Given this list of marker genes KCNA5, C1QC, TRDMT1, ST8SIA1, RASL11A, IGF1R, OR1E3, FOXD1, PSMB2, KCNJ11 (potassium inwardly rectifying channel subfamily J member 11), HTR1A, GSTM1, CEBPE, GLI4, CHORDC1, GRID1, KLF10, SMYD5, SCN7A, PNLIPRP1, EFEMP1, ST6GALNAC3, SPAM1, TRBV15, CA2, ATP9A, RHD (Rh blood group D antigen), ADAP1, PCK1 (NCBI Gene Id 5105), TMT1B, CYP11B2, ABCC9, GIP, CEACAM3, PRR4, PZP, INPP5D, NF2, KCNJ2, GMPR, CDC37, DNAH2, GCM1, NEURL3, DIO2, PLG, COMP (cartilage oligomeric matrix protein), CHIC1, GNG7, GPR19, NPPC, TRH, CHCHD6, AVPR1B, DRD3, LCN2, MARK2, TACR1, HAL, MAP2K2, PTH, CLEC11A, PROC, SV2B, KLF6, IRS2, CYP2D6, ZSWIM7, GRHPR, ERGIC1, CBX5, F2RL1, CAMK2N2, GRM5, KCNJ4, CHN1, CD3D, GHSR, CDS1, PFKM, AZGP1, KCNA6, MYH3, RALBP1, ATP4B, CYP2E1, SCNN1B, GRM8, SSTR1, CAMK1D, MC3R, ITGAE, CD52, CUZD1, CYP27B1, UCHL1, CBS, PCCB, INF2, IGF2R, ARRB2, ZNF45, PNOC, SERPINA1, PLAAT5, SULT1C2, TAP1, ACP3 (acid phosphatase 3), MEF2D, PLA2G2A, VIM, CHRNA4, SLC10A1, CRYBB3, PAQR7, SLC13A2, PDE4C, ACCSL, CES1, VTN, MTMR7, THPO, TMEM79, REN, DGKZ, RGS8, ERBB2, ITGB4, UBE3A, PRKCG, HTR7, LSAMP, GSE1, DDIAS, IGFALS, AMBP, MMP28, ADH1C, RPL28, ASS1, LGALS4, FURIN, B3GAT1, MT-ATP6, BMP7, AQP9, SCGB2A1, PCP4L1, THBD, TAT, PMFBP1, CRYBA1, HSD17B4, MAS1, NDUFB5, GRIK4, CACNB4, UCP2, MYH6, FBXW5, SLC22A1, MCF2L, TAC1, ADCYAP1 (NCBI Gene Id 116), ACVR2A, CACNA1H, UGCG, CHRM5, OPRD1, GPAM, ADAP2, AKR7A3, CD247, PPP1R3B, FGR, FAT2, SLC15A1 (NCBI Gene Id 6564), CLDN3 (claudin 3), TFF3, EDN2, PLCD4 (NCBI Gene Id 84812), STRN, MAPKAPK3, PPP1R13L, GNA15, KRT36, SKIC2, MMP9, ADRB1, DOCK8, C1orf210, SLC6A9, CAMK2G, BCL2, PRB3, NPR1, NPPA, CYP11B1, PFKFB2, CRP, MSH2, CBLIF, TSGA10, MADD, MECR, RGS9, PTPRU, PPP1R9A, CCR2 (NCBI Gene Id 90262), SLC13A3, SLC6A12, SLC5A2, PRB1, PON1, OPRPN, SLC8A3, CASZ1, FBXO38, ACE, ICAM2, HLA-DQA1, WDR37 (NCBI Gene Id 22884), TRAPPC14, CHRNE, AGXT2, SHOX2, TANGO2, CALM3 (calmodulin 3), NAP1L1, POU1F1, NOS2, RGS22, OR6A2, CABIN1, NGFR, CYBA, CRYBB1, SFTPB, SLCO1A2, ZG16, ARHGEF4, P2RY6, STX7, PRLH, BCL2L15, DSEL, GABRA6 (gamma-aminobutyric acid type A receptor subunit alpha6), MEP1B, MRPL50, EPOR, SHH, SLC37A4, PLEKHA1, NKX2-1, KIF1C, AQP6, GALR3, BOK, DLGAP2, CLPS, ZNF687, RPL11, POU3F2, HLA-DMA, CCNB1, CRISP2, MYL1, VEZF1, BDKRB2, CNKSR2, CCK, ALPI, NME6, PTGER1, H2BC7, APC, PIP4K2B, HLF, EGFR, IL1RN, PPT2, TGFBR3, SH2B2, KCNAB3, SERPINA3, PTGER4, ETS1, MGMT, FGGY (FGGY carbohydrate kinase domain containing), KRT8, TIMELESS, GNAS, PPA2, DLAT, NTRK2, BIN1, KCNH2, EFNB1, MS4A2, LEP, SDS (serine dehydratase), WDPCP, FGFR4, PSMB8, KYNU, GPX1, AQP2, NAT1, S100B, SI, CFP, PDE3A, RAB1B, RHBDL1, TBXA2R, RABIF, LPL, CLTA, GHRHR, CPB1, KCNS1, PRM2, GP5, ARFGAP1, PTOV1, MAP3K1, GRIFIN, TOMM34, RPS27L, CNGA1, ABAT, CDKN1A, NPY, KCNA4, LAMA3, COX8A, HOXA4 (NCBI Gene Id 3201), CAPN3, CRYGA, RAD18, SLC27A2, KCNA3, MAPK3, DCHS1, FKBP4, APOA1, GPX4, SLC8A1, HMGA2, FAAH, F10, GULP1, IL13, SOX17, DPYSL4, GCKR, AGER, KCNH5, AQP8, CACNA1A, INA, VSIR, EGR1, PIM1, PARK7, ADAM18, IL2, KCNE1, JUND, EPCAM, RAG1, NAT8, GSTT2, CASP6, CSPG5, PYGL, ADCYAP1R1, C5AR1, AKAP12 (NCBI Gene Id 9614), HSPB6, DNASE1, SNCA, MXD3, MXI1, CARTPT, POLE3, BRCA2, TEX261, A2M, ARC, HOMER1, ARAF, ADORA3, BCL2L1, MYOC, SYCN, CHRNB2, PYGM, STAR, CITED2, PRSS1, CKMT1B, CA3, ALOX5AP, SYT3, NRCAM, UNC13C, BPIFA2, TCF3, INHBB, ADAR, SLC13A1, CHKB, GNRH1, ENPP6, GJB3, UROD, RGS18, TNFRSF4 (NCBI Gene Id 7293), INS, DPP6, MISP3, MYO1B, PDE2A, PDE1B, HOXD3, GPT, KL, ACOX3, CACNA1D, FUT4, INSRR, CSN3, PLEKHM2, PACS1, DPYS, SOX10, ST3GAL3, CTRC, P2RX3, CCL11, CLDN7, GRIN2D, IL1R1, PLAUR, NDUFB6, SLC6A17, PSMA1, SST, ACTC1, PPARA (peroxisome proliferator activated receptor alpha), DPF1, GUCA2B, RNF112, MMS19, GRIA1, RARA (NCBI Gene Id 5914), ATXN1, CSRP3, FAM234A, DTNBP1, CYP2C18, GDF10 (NCBI Gene Id 2662), CXCR1, SLC22A7, CSF2RB, SHC3, SERPINI2, ALOX15, AQP7, ACVR2B (NCBI Gene Id 93), GMEB2, HR, ESRRA, PHB1, ABCC8, IGLC1, CHRNA6, SH2B1, TYMS, ARNT, HAND1 (heart and neural crest derivatives expressed 1), PCSK7, CES2, HOOK1, UGT2B7, OSBPL2, BFSP1, JUN, CRHR1, JAK2, GLP1R, UGT1A10, SOX13, CD8A, RAB3A, PTGFR, DRD1, ADRA1D, NEFL, SULT2A1, ACOX2, DLG2, PIGR, MX1, DDN (NCBI Gene Id 23109), ALDOB, KCNJ10, MMP7, RAB26, DYNC1LI2, GDE1, IGF2, CALCRL, ERRFI1, SYT2, GJB5, ACHE, GP2, CYP4A22, NAE1, CCL3, SULT1C3 (sulfotransferase family 1C member 3), TBP (TATA-box binding protein), CNTN1, RXRB, CALB2, IL10, HSPB2, CACNA1C, PHOX2A, OR1F1, PPP2R1A, KLK8, GFAP, LIF (LIF interleukin 6 family cytokine), HSD3B1, NUDT6, PPP1R1A, GYS2, FGF16, CYP2C8, PIP4P1, MASP1, RAB4A, ETNK2, UGT2A1, MTRF1L, CREG1, MAP3K9, AK2, NDUFS8 (NCBI Gene Id 4728), KLKB1, MAPK12, SPTBN2, SLC7A2, MYL3, PDX1, IGFBP1, SFTPA1 (surfactant protein A1), MUC2, DUT, CD74, PRL, ACVR1B, CEACAM4, LTA, RIMS1, RNF113A, SCN3A, PDE4D, CA6, TF, KCNA2, GAL, ATP2B2, MYL12B, GSS, DHFR, HAND2, NEUROG1, IMPA1, P3H4, GABRG1, DLGAP3, GZMH (NCBI Gene Id 90562), TRPV1, UNC5A, LCT, GSK3B, AFDN (afadin, adherens junction formation factor), CNTN2, CHMP1A, RHO, EDN3, GPX6, LYZ, SLC34A1, CSH2, TBXAS1, CYP4F8, GABRD, DYRK1A, NTRK3, CDK16, CDH17, AVPR2, NDUFA5, MUC13, CCND1, SYNGR1, MAOB, ELAVL4, CEP95, SERPINA5, CYP1A1, FXYD1, RBP1, DRD2, CTNND2, IGF1, OR8D1, SEMA3A, TST, CDH22, NUP58, PRKCA, IL9, PISD, ECHS1, SERPINB5, CALCA, OTX1, BHMT, SLC6A11, GCGR, EIF2S3, ACAN, RARB, SRD5A1, HES1, KCNJ5, IDE, AKAP1, PLEK, UCP3, FOXG1, C2CD4A, SMR3A, LIN7B, CAMKV, HSD11B2, STX8, AGTR1, HMGCS2, KCNJ1, MPV17L, CUBN, MUC1, EGR4, FGF5, GPX5, OLAH (oleoyl-ACP hydrolase), HPGD, CYP2G1P, ACVR1C, AMPD1, MUC4, GNG11, CSAD, SLC6A2, GJA5, LHB, PRPSAP2, MOGS, USP7, KIT, CST8, CHRM1, ZNF665, MAG, NR5A1, PNCK, CRPPA, DNAH9, CAMK4, GRIK1, CXCR2, PADI2, PRLR, CTSS, ACE2, VPS33B, GSTA2, AP4S1, COX6A2, NR0B2, ALPL, DNAH1, FOXM1, TNNI3, NOS1, NPTX2, FSHB, OPLAH, SEMG1, DNPEP, UNCX, PRKG2, DNAH6, CMKLR2, NRGN, GCH1, KLRG1, HES3, EIF5B, HES5, HPD, SYK, MYO1A, CDC14B, PRKCB (NCBI Gene Id 5579), NT5C1A, NALCN, BEGAIN, TMEM120A, PTPRC, DLC1, SLC10A2, KITLG, HPCAL4, POU2F1, IFNG, DNASE1L3 (NCBI Gene Id 1776), GRM3, PPIF, SELL, MSMB, DPP4, KCNT1, BCAN (brevican), PSMB5, GSTA4, CFTR, SLC9A2, UNC13A, APBB1, EPHX2 (epoxide hydrolase 2), CSNK1D, LYVE1, NTHL1, EFNA5, ALOX5, HLA-DOB, FABP1, TAP2, NTF4, CYP4F2, HNF1B, KCNK1, EEF2, CLCNKA, SULT1E1, CNGA3, OR4B1, ADRA2A, ACOT2, IL1RL2, GLMN, CYP7A1, GJB1, IL18, STAT5B, DLGAP1, MYL2, ITPR1, GRIN1, SYNGAP1, PLCG2, GPC2, PPIG, CASP2, PGR, MGST3, REG1A, ASGR1, ZNF280D, PDGFB, SLC1A6, APBA2, ITPKB, ATP1A3, CDH16, DLST, MECP2, SSBP2, OR51E2, PKIB, TNXB, SCG5, ASL, CXCL14, SOD1, L1CAM, FGF10, MT3, CADM1, SLC15A4, SCARB2, CAMK2A, FAU, HK1, GNB3, CDC7, HTR4, NAALADL1, GNAL, AGXT, HCRT, GDF15, LPAR2, C8B, ADAM5, TRIP10, HMOX1, ETFDH, CHST10, CRYAA, CRYBB2, ADGRL2, PTPRE, FANCC, PVALB, KCND3, BAG6, MIF, CDO1, CRHBP, EDNRA, PIK3CD, R3HCC1, FGB, CCND3, PSMB4, RPL6, GNMT, MAP4K1, C2, ADRB3, HYAL2, HTR1F, SH2B3, PAX4, SLC6A13, RTN1, RPL32, BOD1L1, PPY, IL12B, SNCG, BTG3, HP, LRRC7, KCNC3, RUVBL2, FEM1A, CACNB3, ISL1, MTNR1A, VTCN1, APH1A, DNM1L, AGT, KLRK1, DBN1, IER3, RAPGEF4, NGF, GRIN3A (NCBI Gene Id 138370), HYOU1, DYNLT1, PTPRF, CRYGC, GABRG3, MYO5B, SELENOP, SYT7, SPP2, CYP2A6 (cytochrome P450 family 2 subfamily A member 6), ESR2, ATP4A, TPSB2, UCN, DHRS7B, CCL2 (NCBI Gene Id 6347), TRHDE, NR5A2, UQCRFS1, NLGN3, RPS15, DEFB1, MMRN1, RASSF9, PLA2G5, MAP2, NEDD8, SRSF3, PTGER3, FXYD2, CPLX2, KCNJ16, MAT2A, DNAAF8, FCGR2A, EXOC7, BARHL2, ADH7, MRPL38 (mitochondrial ribosomal protein L38), OCM, SLC1A1, GPRC5C, HMGA1 (high mobility group AT-hook 1), SCN9A, SLC17A1, TNR, PDGFRA, MGAT5, THBS4, OXTR, KCNN3, AP3M2, ATP7B, OPRM1, ITGB3, TRAV12-2, DNAAF1, KCNK5, TEDDM1, MPP3, PSTPIP1, MYT1L, BUB1B, GGT1, MAP1B, TNP2, ZP1, LHCGR, FEZ1, AQP3 (aquaporin 3 (Gill blood group)), PFKFB3, CAP2, IL1A, CCKAR, NDST1, KCNH7, MAPK14, TTLL5, CHRNB4, S100A1, SPRR1A, GALNT5, KCND2, KCNC2, ASIC2, KCNK3, PPP1CA, HAAO, STX1A, FGD4, GHRH, INHA, KCTD13, LGALS7, PIP, C1QB, DDC, NXF1, CYP2C19, CRYGD, GFI1 (growth factor independent 1 transcriptional repressor), CLCNKB, KCNH3, MYCN, CD79B, DDB2, MTHFR, RPS27A, CHRNB1, BDNF, CACNA1S, OTC, OXT, ANP32A, GRM1, PSMD1, CYP2F1, MUSK, DUSP7, FOXI2, KCNB1, UBB, CNGB1, TPSD1, PRKCZ, ITPKA, DUSP4, KIF3C, ATP13A1, WDR62, OPRK1, NMRK2, SNAP25, LIN7A, CYP2B6, KMT2A, KHK, RPS25, FABP6, SLC4A3, SERPINA10, SSTR2, SSB, MADCAM1, NEU2, CALCB (NCBI Gene Id 797), SSTR4, CPA3, TACSTD2, KCNC4, GALNT6, CXCL6, COX5B, ANK3, PTK2, TNP1, NDRG4, MAT1A, ZNF429, HSPB1, TLR4, KCNJ8, GUCY2C, MEP1A, LHX2, OR1E1, CHGB (chromogranin B), JAG2, FDXR, COL26A1, EPB41L4B, TNF, NDUFA4L2, FAM83F, NCAPG2, TFF1 (NCBI Gene Id 7031), PADI1, EPO, RAB3B, CHRNA2, NOTCH1, HTR2A, KRT18, ATP1B2, PSME1 (NCBI Gene Id 5720), SLC28A1, SYNPO, IGLL5, PTPRQ, GAS7, PRG2, HOXB7, POLG2, PNLIP, FGF17, SAMD1, ARL11, HCK, TNNI2, ACAA1, REEP2, NLGN2, VAMP2, KIF27, USP40 (NCBI Gene Id 55230), MSX2, COLQ, SPR, AK1, EGFL7, TREH, ZP3, MMP10, SCGB1D1, TEF, MYL6, POMP, KCNA1, SLC5A1, GABRG2 (NCBI Gene Id 2566), TSHR, KCNAB2, GABRR3, COX7B, SLC6A7, CCDC88C, SH3GL2 (SH3 domain containing GRB2 like 2, endophilin A1), DEAF1, SLC22A9 (NCBI Gene Id 221106), HRK, SCNN1A, SH3KBP1, PIP4K2C, PCSK4, SLC1A2, GABRA3 (gamma-aminobutyric acid type A receptor subunit alpha3), PTPRH (protein tyrosine phosphatase receptor type H), NELL2, HADHA, RTN4IP1, IRF2, PSEN1, SLC24A2, NMU, GPR15LG, S100G, BAX, WDR31 (NCBI Gene Id 114987), DBP, ARHGAP28, DLG1, GALM, KCNJ6, NCAN, CYP17A1, TTPA, MMP3, CXCR4, IGFBP3, RESP18, CAPN5, DACT2, FGA, FOXD3, PLAGL1, DLX5, FOXA3, CD3G, APOB, IL9R, NFIC, MAPT, ZSCAN25, CCL20, CAMKK2, GABRR2, TACR2, SIRPA, LIMK1, RFWD3, MAP2K5 (mitogen-activated protein kinase kinase 5), SLC12A5, CTSC, ERBB4, VN1R17P, ADAM2, MMP23B, RALGDS, HIVEP2, ENTPD2, MGAT2, RBP4, STARD8, TMEM171, GRIA3, HTR5A, VSNL1, RALGAPA1, KCNH8, DPEP1, MAP6, SCN1B, ARF3, CKMT2, ALDH1A1, ODF1, BCAR1, PTPN3, POLR2H, COL9A1, KLRB1, DDR1, SAMD4B, KRT5, SOCS3, PLA2G2C, CGA, ATP2A3, HTR2C, IGFBP2, HSD17B3, CAMK2B, TMA7 (translation machinery associated 7 homolog), BEND7, CLEC9A, FRMD5, S100A7L2, GABRB3 (gamma-aminobutyric acid type A receptor subunit beta3), LDHC, TTN, CDC25B, SLC8A2, NEFH, PAK3, STRN4, LGALS9, ADRB2, EGR3, TNC, PDE4A, FBXO2, GZMB, SYT9, PLA2G1B, TPM3, DLL3, NSG1 (neuronal vesicle trafficking associated 1), ERBB3, PHAX, RAF1, MAK, CEACAM21, KCNQ3, CYBB (NCBI Gene Id 1536), P2RX1, OLFM1, KRTAP1-5, EIF2AK3, STXBP2 (NCBI Gene Id 6813), PFKFB1, PHKG1 (phosphorylase kinase catalytic subunit gamma 1), RAB3C, PTPRN, FUT1, MRAS, RGS1, SEMG2, HMBS, DEFB4B, APOBEC1, FGF14, PLLP, CD53, GRPR, MAPK8IP2, IVL, SCNN1G, SCG3, UTS2R (NCBI Gene Id 2837), TRHR, PRIM2, EPN1, CLCN1, CTRB2, MIP, PIK3C2G, BAZ2B, CACNG1, CCR1, here is a description of the gene set: Human Gene Set: YOSHIMURA_MAPK8_TARGETS_UP from publication Yoshimura K, Aoki H, Ikeda Y, Fujii K, Akiyama N, Furutani A, Hoshii Y, Tanaka N, Ricci R, Ishihara T, Esato K, Hamano K, Matsuzaki M (PMID 16311603) Abdominal aortic aneurysm (AAA) is a common disease among elderly people that, when surgical treatment is inapplicable, results in progressive expansion and rupture of the aorta with high mortality. Although nonsurgical treatment for AAA is much awaited, few options are available because its molecular pathogenesis remains elusive. Here, we identify JNK as a proximal signaling molecule in the pathogenesis of AAA. Human AAA tissue showed a high level of phosphorylated JNK. We show that JNK programs a gene expression pattern in different cell types that cooperatively enhances the degradation of the extracellular matrix while suppressing biosynthetic enzymes of the extracellular matrix. Selective inhibition of JNK in vivo not only prevented the development of AAA but also caused regression of established AAA in two mouse models. Thus, JNK promotes abnormal extracellular matrix metabolism in the tissue of AAA and may represent a therapeutic target. Genes up-regulated in vascular smooth muscle cells (VSMC) by MAPK8 (JNK1). studied in species Rattus norvegicus